Given this list of marker genes PLA2R1, MIF, NTSR1, PLA2G10, AVPR1B, here is a description of the gene set: Human Gene Set: GOBP_POSITIVE_REGULATION_OF_ARACHIDONATE_SECRETION species: Homo sapiens Any process that increases the rate, frequency, or extent of arachidonic acid secretion, the controlled release of arachidonic acid from a cell or a tissue.